Given this list of marker genes ADIPOQ, GNA12, MYOCD, NFE2L2, MIR665, MIR214, MIR424, MIR503, TPM1, MIR182, BMP4 (NCBI Gene Id 652), MIR140, NF1, MIR362, MIR34A, MIR638, PTPN1, MIR137, MIR223, MIRLET7B, MIR1298, MIR218-1, MIR21, MEF2C, PRKG1, MIR15A, here is a description of the gene set: species: Homo sapiens Any process that stops, prevents or reduces the frequency, rate or extent of vascular associated smooth muscle cell migration. Human Gene Set: GOBP_NEGATIVE_REGULATION_OF_VASCULAR_ASSOCIATED_SMOOTH_MUSCLE_CELL_MIGRATION